Given this list of marker genes Agt (NCBI Gene Id 11606), Cntnap2, Il1b, Ace2, Aplnr, Tbx5, Hopx, Irx3, Ace, Cav1, here is a description of the gene set: Mouse Gene Set: GOBP_REGULATION_OF_GAP_JUNCTION_ASSEMBLY Any process that modulates the frequency, rate or extent of gap junction assembly. species: Mus musculus